The following is a description of a gene set: species: Mus musculus Mouse Gene Set: chr11C, and this is the list of marker genes: Ccl8, Ppm1e, Septin4, Aatf, Smg8, Appbp2os, Gm22883, Pex12, Trim25, Akap1, Myo19 (NCBI Gene Id 66196), Supt4a, Atp5k-ps3 (NCBI Gene Id 11963), Rasl10b, Hsf5, Dhrs11, Rnft1, Pigw, Tbx4, Gm11444, Slfn8, Tada2a, Gm11423, Bcas3, Car4, Ccl1, 1700109G15Rik, Fndc8, Heatr9, Gm22387, Rpl13-ps1, Gm38577, Gm26439, Zfp830, Gm11509, Mks1, Wfdc21, Wfdc17, Ddx52 (NCBI Gene Id 78394), Gm11426, Akirin1-ps (akirin 1, pseudogene), Slfnlnc, Scpep1, Vmp1, Ap2b1, Cct6b, Cuedc1, Appbp2, Gm11427, Ccl2, Lhx1os, Epx, Trim37, Gm11510, Ccl3, E230016K23Rik, Mir378b, Nog (NCBI Gene Id 18121), 2210409E12Rik, Gm11420, Ints2, Mpo, Dusp14, Gm23951, Mir5110, Hnf1b, Ypel2, Gm2018, Slfn4, Mtmr4, Dgke, Mrm1, Mmd, Or4d1, C030037D09Rik, Gm11494, Unc45bos, Atp5l-ps2, Tubd1 (tubulin, delta 1), Gm11437, Vezf1, Gm11424, Tspoap1, Znhit3, Mir142hg, Gm11496, Ptrh2, Gm31522, Slfn3, Mir301, Pctp, 1190001M18Rik, Elobl, 1700020L24Rik, Rffl, Gm11507, Acaca, 1110028F11Rik, Dynll2, Gm22534, Ccdc182, 4930556N13Rik, Msi2, Srsf1, Tmem132e, Cltc, Gm11478, Heatr6, Mir142b, Slfn9, Chct1, Gm11434, Med13, Gm525, Rad51d, Gm25968, Dhx40, Brip1os, Gm12576, Ccl5, Brip1, Bcas3os2, Synrg, Usp32, Tbx2, Slfn5os, Wfdc18, 4930502E09Rik, Mrps23, Hlf, Mir142, Gdpd1, Lpo, Ggnbp2, Rad51c, Ccl9, Smim36, Taf15, Rps6kb1, Snord7, 2610027K06Rik, Slfn14, Rnf43, Ska2, Gm11443, Ccl12, Mmp28, Lhx1, Ccl4, Rpl9-ps1, Slfn5, Gm11432, Slfn10-ps, Coil, Ccl11, Ppm1d, Tmem100, Unc45b, Gas2l2, Gm11433 (NCBI Gene Id 102635563), Slfn1, Slfn2, Ccl6, Ccl7, Gm9378, Ankfn1, Gm38534, Lig3, Prr11, Scpep1os, Bcas3os1, Tex14, Or4d2, Gm11497, Gm23507, Dgkeos, Gm11425, AA465934, Mir21a (NCBI Gene Id 387140), Or4d2b, Nle1, Gm11422, Gm11430